Given this list of marker genes Pcdhb5, Adamts5, Cypt12, Clxn, Ndufc2, Cd24a, Aass, Mpeg1, Zfp870, Dpys, Prdx2, Enah, Cypt4, Pcdh20, Cyp2ab1, Zfp36l2, Tor1aip2, Reep6, Hlf, Nol4l, Loxl3, Sema6a, Hcn1, Ccl28, Adamts6, Mobp, Ugt2a3, Trim42, Spmip6, Spry4, Gpr82, Slc11a1, Orc4, P4ha1, Fam32a, Spag9, Clec12a, Cypt3, Col23a1, Htr2a, Hcn3, Cyp46a1, Ppp1r2, Cypt1, Entpd1, Fgf7, Fbxo34, Serpina1f, here is a description of the gene set: Genes predicted to be targets of miRBase v22 microRNA mmu_miR_7044_5p in miRDB v6.0 with MirTarget v4 prediction scores > 80 (high confidence targets). species: Mus musculus Mouse Gene Set: MIR_7044_5P from publication Chen Y, Wang X (PMID 31504780)